The following is a description of a gene set: from publication Nakaya HI, Wrammert J, Lee EK, Racioppi L, Marie-Kunze S, Haining WN, Means AR, Kasturi SP, Khan N, Li GM, McCausland M, Kanchan V, Kokko KE, Li S, Elbein R, Mehta AK, Aderem A, Subbarao K, Ahmed R, Pulendran B (PMID 21743478) species: Homo sapiens Human Gene Set: GSE29618_PRE_VS_DAY7_POST_LAIV_FLU_VACCINE_BCELL_DN Systems vaccinology has emerged as an interdisciplinary field that combines systems wide measurements and network and predictive modeling applied to vaccinology. Here we used the systems vaccinology approach to study the molecular mechanisms underlying th Genes down-regulated in comparison of B cells from LAIV influenza vaccinee pre-vaccination versus those at day 7 post-vaccination., and this is the list of marker genes: GID4, TTC28 (NCBI Gene Id 23331), PPIAL4A, ZNF749, SLC25A30, LINC00837, SERPINB3, SPHK2, RPS17P5, LSM14A, ZBED2, FKBP14, AHSP, FOXM1, AMN, SSR1, CYP4F3, SEC63, YIPF2 (Yip1 domain family member 2), PTPRH, FAM120C, TSSK2, VEGFD, SMIM10L1, PAIP2B, CDHR5, FERMT1, C3orf36, DBP (D-box binding PAR bZIP transcription factor), PDK3, NPRL2, GRK6, BAIAP3, IFT81 (intraflagellar transport 81), RGS20, FBXO22, PRL, NECTIN3, PGBD5, TAS2R9, S100A13, TMEM160, HPCAL1, GLYAT, BTAF1, RNF39, SPICE1, GULP1, PLA2R1, DHX29, ABHD4, CD19, MKI67, RNF144A, CHST7, IL5, PGLYRP4, ACOT11, GBA3, HOXB2, PDE7B, HSF1, TEK, TCF7L1 (transcription factor 7 like 1), GATA6, NBL1, CAMTA1, SLC18A3, MLLT11, PHF7, SUV39H2, CETN1, C14orf132, IGLV4-60, GABRE, VIL1, PUS1, SNRNP200, AVP, SKA1, CTAGE1, OR10H1, GEM, FANCE, NCBP2, RIOX2, MAGOH, RPL10P17 (NCBI Gene Id 390998), HDLBP, SRPRA, CLPTM1, GPR50, CACNA1G, DNAJC10, ACADSB, ARPC1A, DENND6B, PCDH7, VANGL1, ZNF468, QTRT1, PARP2, SNAP25, CXADR, FGF9 (fibroblast growth factor 9), SLC13A3, QDPR, IL37, TXNRD2, LRRC31, EFNB3, GALR1, SEC24D (SEC24 homolog D, COPII coat complex component), PSEN2, ITGB1BP1, LORICRIN, NXPE3, NID2, ZNF365, ATG4A, MFGE8, SLC37A4, CCL20, SEC31B, INTS1, ATAD5, NAP1L2, CLDN4, NT5E, IFT57, MBD5, ATM, ASTE1, INTS7, LAPTM4B, SPRYD7, BDNF, ANKRD27, WNK1, ADAMTS9, POMGNT1, UBE3B, C2orf68 (NCBI Gene Id 388969), RPL23AP7, LDHAL6B, SLC6A12, SLC22A11, SLC6A13, SCLY, JUN, TAF1D, DPYSL4, PRDM1, TK1, RNASEL, CD28, EXOG, SRCAP (Snf2 related CREBBP activator protein), ERCC6, CAPN11, SLC5A2, LRP2BP, PRR15L, GRAP2, NPY5R, EPRS1, ITK, LRRC1, CST6, HEXA, CHRNB1, MTCH1, ARMC6, WSB1, TTR, TTLL12, ZSCAN12, TSPAN4, NME6, USP1, KLF17P1, SIRT2, SRBD1 (S1 RNA binding domain 1), RGS3, LUM, RAC3, PCDHGB6, KRT14, KIF5C, FEZF2, ADSS2, SERPINI2, KLK11, CROCC, ACVR2B-AS1, GFRA1 (GDNF family receptor alpha 1), DCAF17, AIRIM, CALML5